The following is a description of a gene set: Any process that activates or increases the duration or quality of non-rapid eye movement (NREM) sleep. species: Mus musculus Mouse Gene Set: GOBP_POSITIVE_REGULATION_OF_CIRCADIAN_SLEEP_WAKE_CYCLE_NON_REM_SLEEP, and this is the list of marker genes: Ghrh, Ghrhr, Npy2r, Ptger3, Mtnr1b, Ptger4, Ghrl, Casp1, Alb